The following is a description of a gene set: species: Homo sapiens Human Gene Set: HUANG_DASATINIB_RESISTANCE_DN from publication Huang F, Reeves K, Han X, Fairchild C, Platero S, Wong TW, Lee F, Shaw P, Clark E (PMID 17332353) Dasatinib is a multitargeted kinase inhibitor that was recently approved for the treatment of chronic myelogenous leukemia and Philadelphia chromosome-positive acute lymphoblastic leukemia with resistance or intolerance to prior therapy. It is also in clinical trials for treating patients with solid tumors. The identification of molecular markers predictive of response to dasatinib could assist in clinical development by selecting patients most likely to derive clinical benefit. Using baseline gene expression profiling of a panel of 23 breast cancer cell lines, we identified genomic signatures highly correlated with in vitro sensitivity to dasatinib. The ability of these signatures to predict dasatinib sensitivity was further confirmed and validated in independent test cell lines. A six-gene model was used to correctly predict dasatinib sensitivity in 11 out of 12 (92%) additional breast and 19 out of 23 (83%) lung cancer cell lines. Quantitative real-time PCR and immunohistochemical assays further confirmed the differential expression pattern of selected markers. Finally, these gene signatures were observed in a subset of primary breast, lung, and ovarian tumors suggesting potential utility in patient selection. The subset of breast cancer patients expressing the dasatinib-sensitive signature includes a distinct clinical and molecular subgroup: the so-called triple negative (i.e., estrogen receptor-negative, progesterone receptor-negative, and HER2-negative) or basal breast cancer subtype. This patient population has a poor prognosis and currently has few effective treatment options. Our results implicate that dasatinib may represent a valuable treatment option in this difficult-to-treat population. To test this hypothesis, clinical studies are now under way to determine the activity of dasatinib in these patients. Genes whose expression negatively correlated with resistance of breast cancer cell lines to dasatinib., and this is the list of marker genes: TRIM13, ACSL3, IGFBP2, CBX5, GREB1, EPB41L5, BBIP1, DNPH1, MAPT (NCBI Gene Id 8152), TMEM229B, SCARB1, YME1L1, PREX1, ABCA3, TRPS1, ISOC1, CHRM1 (NCBI Gene Id 92150), CA12, SLC1A2, SPIN1, TBC1D30, SORBS2, ABCG1, CLN3, MYEF2, TOB1, SLC35A1, MEGF9, GPD1L, PRLR, TFF1, CYB561, ELAPOR1, CRNKL1, EPS15L1, ARX, C14orf93, CALM1, ASCL2, ICA1, DEGS2, SLC38A1, HID1, JPH1, MIX23, SBK1, EIF4E3, CLDN3, CERS6, ABHD11, UBL3, PLCH1, LUC7L3, ACSS3, PDCD4, VPS37C, SLC16A6, IRX5, CDC42SE1, PLEKHH1, CREB3L4, NSUN5P1, TPD52, CHPT1, PLCB4, SLC25A15, STARD10, EMP2, METTL9, RHOB